The following is a description of a gene set: Mouse Gene Set: GOBP_GLUCOCORTICOID_SECRETION species: Mus musculus The regulated release of any glucocorticoid hormone into the circulatory system. Glucocorticoids are a class of steroid hormones that regulate a variety of physiological processes, in particular control of the concentration of glucose in blood., and this is the list of marker genes: Crhr1, Crh, Tspo, Galr1, Tac1, Selenom, Gal, Ghrl, Cry1, Ecrg4, Pomc, Kcnq1, Nrg1, Cry2, Ptpn11